Given this list of marker genes CHRNB1, HOXD9, EN1, NRXN1, NPC1, CRHBP, AGTPBP1, FKRP, ZMPSTE24, TMOD1, NR4A2, CARTPT, OXR1, NPY, APP, ATP6V1B1, ALK, ZFHX2, LEP, CHRNA5, NTAN1, PUM1, CHRNA3, NLGN2, CNTNAP2, TUBA1A (tubulin alpha 1a), CSTB, ARRB2, GLRA1, ATXN1, CDK5, SNCA, USP46, EFNB3, DRD3, GIP, GRIN2D, PARK7, DMBX1, HIPK2, SLITRK6, SEZ6, SLITRK5, GBX1, EHMT2, ABHD12, INPP5F, NRXN2, SLC1A2, PTEN, CHL1, EPHA4, MECP2, OPRK1, BBS4, OPRD1, TBCE, BRS3, PBX3, GHSR, GHRL, NCSTN, ZIC1, MAFG, GLRB, HOXD10, EPS8, PAX5, PRKN, HEXA, ADAM2, CHRNB4, FXN, KCNJ10, SPTBN2, PAFAH1B1, FGF2, PPT1, SEPTIN5, PREX2, LGI4, FOSB, DRD2, PPARA, VPS13A, BBS2, WDR47, SHANK3, DRD1, GABRG2 (gamma-aminobutyric acid type A receptor subunit gamma2), UCHL1, CLCN3, GDNF, FOXA2, CEND1, HTRA2, SLC7A11, PCDH17, AGRP, DBH, NTF4, FGF12, SHANK1, HOXB8, ID2, NAGLU, CHRNB2, SCN1A, CLN8, FADD, CRHR1, CHRNA4, RNF170, DRD4, GRM2, TPGS1, CACNB4, TSC1, HDAC2, GIGYF2, ASIP, SLITRK1, OPRM1, CXCL12, DMRT3, CNTN2, CNP, NRXN3 (NCBI Gene Id 9369), NLGN4X, TRH, SLC1A1, SHANK2, CCND2, HOMER1, SLC6A4, HOMER2, CTNS, BTBD9, ARCN1, PPP1R1B, KLHL1, CHRNA6, SNCG, NLGN3, SDK1, BBS1, CHD7, NR4A3, SPTBN4, RNF180, ATP1A2, DAB1, NTSR1 (neurotensin receptor 1), HTR2A, here is a description of the gene set: Human Gene Set: GOBP_ADULT_BEHAVIOR species: Homo sapiens Behavior in a fully developed and mature organism.